The following is a description of a gene set: species: Homo sapiens An increased proportion of mast cells are positive for the cell surface marker CD25 (also called interleukin-2 receptor alpha chain). Increased proportion of CD25+ mast cells Human Gene Set: HP_INCREASED_PROPORTION_OF_CD25_MAST_CELLS, and this is the list of marker genes: TET2, CBL, SRSF2, ASXL1, LYST, RUNX1